The following is a description of a gene set: Mouse Gene Set: GOBP_RENAL_TUBULAR_SECRETION The elimination of substances from peritubular capillaries (or surrounding hemolymph in invertebrates) into the renal tubules to be incorporated subsequently into the urine. Substances that are secreted include organic anions, ammonia, potassium and drugs. studied in species Mus musculus, and this is the list of marker genes: Ednrb, Nr3c2, Umod, Cyp2j5, Slc5a2, Spx (spexin hormone), Abcg2, Cln3, Mllt6, Drd2, Nherf1, Comt, Edn1, Stc1, Corin, Slc22a6 (NCBI Gene Id 18399), Atp6v1b1, Atp6v0a4, Abcg3